Given this list of marker genes Cd24a, Irf2bp2, Foxp1, Rag1, Kit, Mir18, Prkdc, Abl1, Syvn1, Mir20a (microRNA 20a), Rag2, Mir17, Mir92-1, Laptm5, Traf3ip2, Mir19a, Spi1, Fnip1, Atm, Lrrc8a, Atp11c, Tnfsf13b, Spib, Mir19b-1, Ighm, here is a description of the gene set: studied in species Mus musculus Mouse Gene Set: GOBP_IMMATURE_B_CELL_DIFFERENTIATION The process in which a precursor cell type acquires the specialized features of an immature B cell.